Given this list of marker genes Or14m1-ps1, Ttc19, Retreg2, Tmem129, Hspa9, Dmap1, Gm10778 (NCBI Gene Id 100233208), 4930509E16Rik (NCBI Gene Id 75115), Snrpc, Cdt1, Raet1e, Krt80, Srebf2, Ints4, Synpo, Slc20a1, Zbtb7a, Camk2d, Zfp175, Nlrp9b, Vps54, Gcc2, Abcf1, Ddx39a, Mir6986, Med27, Phaf1, Rtkn, Dip2c, Runx2os2, mt-Cytb, Lipt1, Sp1, Gm25831 (predicted gene, 25831), Apobec1 (apolipoprotein B mRNA editing enzyme, catalytic polypeptide 1), Gm22507, Elovl5, 5330413P13Rik, Haus8, Senp8, Zfp672, Plec, Wiz, Gpn1, Ddx39b, Fnip2, Frg2f1, Vmp1, Car13, Krtcap2, Vcan, Me3, Smurf2, Pomgnt1, Agpat1, Bnc2, Cnot3 (CCR4-NOT transcription complex, subunit 3), Tmem259, Alg11, Mix23, Mterf4, Mpv17, Galnt13, Appbp2, Dok1, Fh1, Col3a1, Pgd, Slc4a2, Fyco1, Pidd1, Cmpk1, Sema3a, 5430416N02Rik, Sprr2d, Cysltr1, Golga3, Afdn, Cops3, Cep41 (NCBI Gene Id 83922), Gramd1a, Zfp865, 2310022A10Rik, Polr2a, Plekhg1, Polr1c, Gm5210, Zfp740, Gm5475, Prss22, Egr2, C87436, Chml, Gm9826, Calcr, Rbm39, 4930447F24Rik, 1600023N17Rik, Gls, Mbd6, Map3k3, Rbbp4, Ipo8, Notch2, Rpl27, Hapstr1, Mrfap1, Cmtr2, Gins1, Traf7, Dna2, mt-Rnr2, Vmn1r-ps9, Dhrs9, Snrnp40, Or2j3, Ugt2b34, Sppl2a, Luc7l2, Tnfrsf12a, Eif2b2, Khsrp, Racgap1, Mir1934, Ldlrap1 (NCBI Gene Id 230816), Mib1, H3c6, Smyd2, Csnk1g2, Sharpin, Nmt1, Zng1, Terf2ip, mt-Ti, Fam114a1 (family with sequence similarity 114, member A1), Gm15983, Arhgef2, Mir302d, Phip, Eif4e, Appbp2os, Sfr1, Rnf149, Gm13787, Eif5a, Hoxaas2, Bnip2, Rpl23, Snord45b, Slc25a12, Trim46, Gm7626, Ip6k1, Tmem198b, Ccdc142os, Herpud1, Spred3, Btf3l4, Cage1, Tut4, Camkk1, 1810044D09Rik, Gm12825, Sult2b1, Rps25, Rnf111, Ubb, Usp5 (ubiquitin specific peptidase 5 (isopeptidase T)), Zwilch, Rps19-ps11, Clk1, Or2k2, Lrrc72, Ciz1 (NCBI Gene Id 72984), Hnrnpd, Gm22187, Slc35b1, Ccdc30, Alad, Kdm1a, Fem1b, Sec14l1, A430035B10Rik, Tent5c, Fam170a (NCBI Gene Id 225497), Abcb8, Lman2, Armt1 (NCBI Gene Id 73419), Orm1, Rps21, Gm18821, Hibadh, Dusp6, Farp2, Bahcc1, Farsa, Ddx56, Uqcrc2, Gga1, Zfp1008 (NCBI Gene Id 211378), Ddx50, Smim13, Reps1, Gm15122, Akr1c6, Sgk3, Adamts6, Desi2, 6030469F06Rik, Nqo1, Nmt2, Tasp1, Hint3, Rimoc1, Hspbp1, Olfml3, Tapbpl, Spata1, Dazap1, Rab11a, 8030487O14Rik, Snord60, Lmntd1, Map3k4, Tbce, Smarcal1 (NCBI Gene Id 98463), Aup1, Bmf, Mir1956, Efr3a, C1qtnf7, A630031M04Rik, Swt1, Zfp157, Oxct1, Serbp1, Mmaa, Pot1a, Elmod2, Vsig10, Snora73a, Dlgap1, Atxn7l1, Gm12739, Shc1, Numb, Plaur, Gm24903 (NCBI Gene Id 115485990), H2az1, Mtln, Ntaq1, 4633401B06Rik, Actr6, Tgfb3, Map3k5, Gm10193, Acyp1 (acylphosphatase 1), Vgll4, Gdap2, Sf1, Gm12998, 1700069L16Rik, 4930506C21Rik, Tsen34, Gm15727, Oxct1as, Nbea, Zfp560, Ier2, AV039307, Mir3091 (NCBI Gene Id 100526556), Ttc39aos1, Maml1, Or2n1e, Slx4, Ppfia3, Chchd7, Gpr85, Nt5dc3, Esf1, A330087D11Rik, Polr3c, Mir7688, Dcaf8, Copz1, Spty2d1, Gm25977, Gm15527, Tmcc3, Xab2, Fkbp3, Hook3, Rragc, Mars1, Zfp867, Hmgb1, Arhgef26, Yipf3, Tigd3, Nudt13, Tti2, Cdk19, Nlk, Rccd1, Cep78, Rnf5, mt-Nd2, Rnf115, Snd1, Dynlt3 (NCBI Gene Id 67117), Gm19587, Gm26608, Gm11205 (NCBI Gene Id 102632809), Pik3ca, Clasp1, Pias3, B3gnt9, Smim29, Cyb561d1, Ddx59, Rplp0, 4833427F10Rik, Rad54l, Ankrd44, Tsga10, Gm25613, Gm11837, Exo5 (NCBI Gene Id 73172), Coq8b, Hbp1, Rpl28, Zscan2, Hdhd3, Gm2987, Marf1, G630016G05Rik, Uxs1, Txndc11, Cep170, Taco1os, Dgcr8, Dele1, Cul4b, Haus2, Cr1l, Gm14562, Rsf1, Bsdc1, Gm9645, Sox5os1, Ramacl, Slc15a2, Ptbp1, Ifi27 (interferon, alpha-inducible protein 27), Slc1a7, Phf23, Cops5, Rab21, Dnah17, Nfkbil1, Litaf, Ric8a, Slc52a2, Gm28836, Csn1s1, Gm26747, Mrpl12, Pcmtd1, Tmem218, Txndc15, Cdin1, 1700022H16Rik, Top3a, Rab3ip, Pafah2, Cd63, Snx15, Hmces, 2010315B03Rik, Gm47290, S100a6, Optn, Hps1, Gm9869, Cenpp, Slc25a35, AI597479, Or52p1, Gm21719, Heatr5a, Zfp788, Timm21, Inpp5k, Gm42573, Rbak, Gatad2a, Ttc9c, Rps6kb2, Tvp23bos, Cln3, Tst, Lrrc57, Fndc11, Hdgfl2, Hnrnpl, Gm12758, Myo9b, Elf2, Prr11, Ankhd1, Gm12936, Mfsd12, Elk1, Hnrnpdl, Kif20b, N4bp2, Pet117, Wdr73, Yap1, Ppp1r9a, Creb3l2, Ormdl3, Pced1a, mt-Tv, Ccdc186, Cnot8 (NCBI Gene Id 76343), Prmt7, Fbxl20, 2310001K24Rik, Hscb, Ppp6c, Rps27a, Cdan1, Sgcb, Slmap, Fscn1, Ap4s1, Mettl5, Zfyve19, Ipo13, Mindy1, Lin28b, Fbxl15, Gm5773, Oit3, Gm14335, Lrrc51, Dcakd, Or2aj6, Usp30, Zfp260, Sp2, Slc39a14, Zfp948, Grip1, Ifi35, Srsf11, Kcnab1, Arl14ep, Gm5285, Lix1l, Rcc1, Igf2bp2 (insulin-like growth factor 2 mRNA binding protein 2), Tsn, Fiz1, Zfp87, Cfap54, Ap4e1, Pole2, Rnf43, Inpp4b, Gm10484, Zzef1, Apol7d, Zfp719, Fam174a, Gm36535 (NCBI Gene Id 102640487), Eif2a, Gm16833, Gm17057, Cenpo, Parg, Ncapg, Plin2 (perilipin 2), Lgalsl2 (galectin like 2), Kdm4a, Galc, Gm12704, Aldh1l2 (aldehyde dehydrogenase 1 family, member L2), Gm15283 (NCBI Gene Id 102637576), Mettl5os, Tbc1d19, Gm26688, Gm12279, Ccp110, Mtor, Tef, Zfp639, Wsb2, Gm7094, Mier1, Surf2, Rras, Sfpq (NCBI Gene Id 78315), Golga7, Gm15537, BC048644, Setdb2, Mir5133 (NCBI Gene Id 100628602), Ankrd46, Rhoh, 4930442H23Rik, Sumf1, Cnga1, Tsc2, Pcnp, Tet1, Gm13379, Gosr2, Pax9, Trip12, Timm22, Actr3b, Nop14, Selenoi, Zfp229, Ccnl1, Sbds, Armc8, Serf1, Gm3605, Rpa2 (replication protein A2), Prrc2a, Cops4, Pdia4, Kars1, Abhd12, Lig1, Acaa2, Rarg, Zfp462, Gm24668, Mtmr6, Gm20732 (NCBI Gene Id 118568201), Inpp5a, Tgif1, Dcaf17, Eci1, Usp2, Fut8 (NCBI Gene Id 53618), Hspb8, Larp7-ps, Plod1, Or10ag56, Nfe2l1, Tmod1, Leprot, Grn, Yipf4, Slc7a6os (solute carrier family 7, member 6 opposite strand), Zfhx4, Lck, Vapb, Tmem69, Cyb5r3, Zfp114, Marchf6, Ggct, Rundc1, St3gal4, Atf4, Wdr4, Asxl2, Gm15787, Tgfbrap1, Rsbn1, Mir6907, Dhcr7, Chia1, Rrp9, Zfp760 (NCBI Gene Id 240034), Dhx16, Hmbox1, Mir1896, Mia2, Celf2, Tcf12, Sertad2, Mnd1, Sgo1, Ubap2l, Rusc1, Phf14, Tmem123, Ccdc97, Incenp, Adh4, Sil1, Pstk, Mical2, Ppp1r35 (protein phosphatase 1, regulatory subunit 35), Mboat7, Ticam1, 2310008N11Rik, Cavin1, Traf3ip2, Ptges3l (NCBI Gene Id 73635), Zcchc17, Il1rl1, Orai3, Ythdc1, Dnajc10, Dtd1, 4933435F18Rik, Radil, Arl2, Zc3h15, Cdca3, Ndufv3, Atp7b, Dennd1b, Pi4k2a, Clca3a2, Mroh1, Ndufb10, Parp3, Snord15a, Cdc42se1, Slc1a4, Arl2bp, Nub1, Junos, mt-Tm, Gm4890, Bcl2l12, Ogg1, Wdr11, Ift122 (intraflagellar transport 122), Rfc3, Tesk2, Lrrn3 (NCBI Gene Id 16981), 0610010K14Rik, Hira, Ncln, Gm17163, Zfp871, Snora7a, Gm17597, Tyw1, Psmb10, Pick1, Mga, Gm12314, Ppp2r5b, Creb5, Kif2a, Slc7a5, Tap2, H60b, Phtf1, Gm13470, Cltc, Sptlc2, Zzz3 (zinc finger, ZZ domain containing 3), Mettl21a, Pik3r6, Ikbkb, G430095P16Rik, Trappc13, Ccdc40, Setd4, Foxj3, Gm20522, Rps9, Abhd4 (NCBI Gene Id 68688), Spcs3, Osbp, Trib1, Sys1 (NCBI Gene Id 98891), Ccdc17, Psmd11, 4930581F22Rik, Banp, Ppp1r9b, Slc25a44, F730043M19Rik, Rab40c, Rdh5, 5031415H12Rik, Gm43403, Syde2, Gm29346, Mllt10, Cspp1, 5730596B20Rik, Gpr155, Fancm, Kank3, Mettl8, Trim33, Narf, Rpl13-ps3, Pcf11, Lmna (lamin A), Os9, Pex12, Or13p8, Stub1, Gm15783, Ak1, Gm26343, Ska2, Frzb, Rnf13, Gm12829, Cped1, Elob, Gemin7, Gne, Gm24013, Gm11228, 9630013D21Rik, Rnh1, Or5an11, Crlf3, Katnb1, Ccdc163, Mbd4, Fyn, Abcc10, Akr1b1, Tor3a, Gm9889, 9330104G04Rik, 5930430L01Rik, Cdr2l, Or10j5, Lpp, Znhit3, Ankrd54, Hmgb1-rs16, Abcc6, C530005A16Rik, Alkbh3, Mir34a, Abhd1, Gm4744, Gm26671, Gli1, Stxbp5, Zfp128, Gm3203, Poldip3, Cirbp, Mpdu1, Vim, Mir7066, Mysm1 (myb-like, SWIRM and MPN domains 1), Prelp, Parp11, Bet1l, Mrps28, Mcc, Sft2d1, Smcr8, Loxl3 (NCBI Gene Id 16950), Plekhb2, Amy1, Ltbp3, Mical1, Vkorc1l1, Ankrd1, Gm15927 (predicted gene 15927), Lrrc41, Pcmtd2, Samd15, Grk5, C9orf72, Pdp2, Nf2, Rtn4, Gm24377, Psmd14, St6galnac3, Casd1, Exoc5, Commd1, Pet100, Agfg1, Larp6 (NCBI Gene Id 67557), Eppin, Zup1, Nat10, Rfx7, Spag9, Prss58, Wbp1l, Cops6, Pcnx3, Smim20, Prdm4, Rrm2b, Mir367, Rpl5, Angpt2, Ap2b1 (adaptor-related protein complex 2, beta 1 subunit), Olfr1235-ps1, Gm12540, Plag1 (pleiomorphic adenoma gene 1), A730018C14Rik, Ptges, Zfp28, Sgk1, Zfp524, Cfap97, Rabgap1, Mdfic, Msh3, Vmn1r-ps28, Prkrip1, Nol8, Plpp3, Kyat3, Wdr3, Capn10, Gm20186, Pdxk-ps, Lhfpl6, Atp6v0d1, Tbpl1, Ap4m1, Gm6757, Ephb3, Ugcg, Trim37, Zfand2a, Gm40117, Fkbp15, Trim45, Platr27, Gmeb2, Irf3, Gak, Ppp1r12b, Ttc39a, Pla2g15, Pik3r3, Fam32a (family with sequence similarity 32, member A), Bcs1l, Tnk2, Ppa1, Ppp1r13l, Nagk, Mmachc, 4930583I09Rik, Naa15, Gm10819, Uqcrh, Bltp2, Fbxo5, Akap8l, Elp6, Ube2k, Rpl4, Rnf214, Gpd2, Mir22hg, Maf1, Tada2a, Scarna17, Mir302a, Ripor1, Ric8b, Per3, Fryl, Snrnp70, Tpi1, Tns3, Tlcd2, Flrt1, 1300002E11Rik, Cnppd1, Pex6, Cyp2j13, Tmem11, Zfp398, Gm15575, Gm17115, Asah1, Atp6v1g2, 4921539H07Rik, Reg3g, Erlec1, Or5k8, Ccdc15, Pop1 (NCBI Gene Id 67724), Ubn2, Mcm7, Gm4876, Nsd3, Gjb4, Gm38250, Slc1a1, Gm23737, Kcnrg, Ruvbl1, Gm11359, Mme, Vps26c, Exoc4, Vmn2r2, Znfx1, Gm11509, Zeb2, Clp1, Or4c118, Cipc, Mm2pr, Igfbp6, Gm14943, Cpa3, Setd1a, Kat14, Kxd1, 8430423G03Rik, Usp16, Manf, Xiap, Flot1, BC005624 (cDNA sequence BC005624), Cab39l, Mzt2, Rxfp3, Ascc3, Ilf2, Il4i1, Ltbp1, Rida, Dusp1, 0610040J01Rik, Golph3l, 9330111N05Rik, Ptprd, Gm15337, Xylt2, Ulbp1, Atp5pf, Ampd1, C130060C02Rik, Cox18, Gm12257, Arhgef4, 2310015A10Rik, Ndufs2, Mdh1, Glce, Fyb1, AI480526, Snhg3, Pcyt1a, Srp19, Kif1b, Gm22656, Ift52, Gm23119, Tsg101, Traf4, Commd5, Mpst, Fscn3, Gm412, Dact3, Serpinb6a, Wdr62, Aff1, Hook2, Zfp696, Tcf7l1, Nmd3, Pdss2, Snn, Map3k11, Gpbp1l1, Cdc123 (NCBI Gene Id 98828), Muc1, Ghitm, Wasf1, Kctd19, Htra2, Zcchc4, Col6a1, Ppm1k, Zbtb8os, Zfp142, Mtbp, Slc39a10, Gm13877, Serf2, Mfn1, Gm19060, Tnc, Prkra, Gm13498, Pkn2, Abcf2, Rab26os (RAB26, member RAS oncogene family, opposite strand), Foxred2 (FAD-dependent oxidoreductase domain containing 2, NCBI Gene Id 52877), Gm22322, 4933434E20Rik, Myo3b, Cyp4b1-ps1, Ahctf1, Spdye4b, Gstcd, Igkc, Dcaf15, Uqcrq (NCBI Gene Id 98240), Ift74, Tnfrsf1a, Crls1, Ndufc1, Enpp7, Mcrip2, Nubpl, Nr6a1os, Ddb1, Glcci1, Krt13, Arhgap18, Mir1960, Hpcal1, Sftpb, Gm12694, Sema6d, Sh3bp4, Zbtb20, Prkg2, Gdf9, Cfap45, Ttbk2, Rab33b, Gamt, Gm6944, Zkscan5, 1700007F19Rik, Srsf1, Mrps16 (mitochondrial ribosomal protein S16, NCBI Gene Id 66242), Frat2, Klri1, Glrx, Senp2, Uspl1, 1700010K23Rik, Chek2, Zfp790, Golim4, Dcaf13, Trmt11, Mn1, Dcp2, Kdm4b, Trp53cor1, Stradb, Aamdc, Rmnd5a, Sdk1, Zfp385b, Atp6ap1, Cnot6l, Gm19427, Hcar2, Or52r1, Eif4a1, Alg14, Dab2, Dad1, Rbfox2, Wapl, Tcf3, Ddx47, Eif2b5, Agpat3, Sgta (NCBI Gene Id 68091), Pakap, Smurf1, Pappa2, Eci2, Zeb2os, Cfap61, Surf1, Rps3, Rpl21, Dnajb12, Cic, St3gal5, Gm13709, Cyp11a1, Lsm8, Tacc3, here is a description of the gene set: from publication Yevshin I, Sharipov R, Kolmykov S, Kondrakhin Y, Kolpakov F (PMID 30445619) Mouse Gene Set: NKX3_2_TARGET_GENES Genes containing one or more binding sites for (Nkx3-2) in their promoter regions (TSS -1000,+100 bp) as identified by GTRD version 20.06 ChIP-seq harmonization. species: Mus musculus